Given this list of marker genes SFRP2, SATB1, PBXIP1, BBS12, NRXN3, CABCOCO1, SOX21, ESRRG, ARHGAP6, BDNF, RNF181, PTPN7, BIRC8, TLE4, ADSS2, UBE2E4P, POU4F1, ASCL4, BAD, KBTBD12, NXPH4, SEZ6, DLG2, GUCY2C, ADGRB3, BCL11A, SAMM50, FBXW7, OTP, OLFM4, PELO, PAX8, MCAM, CPNE8, CHCHD7, ZHX3 (zinc fingers and homeoboxes 3), YWHAQ, CPA2, LMO2, SLC25A39, PPARGC1A, EXOC6, ELAVL2, GDF1, PYGM (NCBI Gene Id 82368), FAM193B, FAM167A, KCNH8 (potassium voltage-gated channel subfamily H member 8, NCBI Gene Id 131096), JMJD6, CYP7B1, KCTD6, ADAMTS6, SETD2, SH3KBP1, PHEX, RNF152, PROK2, CTSS, PXK, GNA13, GLRX5, SCAF11, CBLIF, GPC4, NNMT, HOXA5, AFF4 (ALF transcription elongation factor 4), HOXD3, FCHSD2, MRPL49, TMTC2, BSND, PCF11, CRIM1, FOXF2, KLF7, ACTB, REEP4, GDNF, TIAL1, ABCA12, DIAPH1, FBXO11, UTP4, ZFP91, PTMA, TMEM150A, RORA, TMEM35A, STRA6, DRD3, MXI1, ZFP36L1, FOXP2, WNT2, MAFG, RUNX3, BMPR2 (NCBI Gene Id 659), PHOX2B, RBFOX1, ASB4, IL1RAP, INO80D, TBX19, SEMA7A, PDGFB, SP8, LCOR, ZNF541 (NCBI Gene Id 84215), TUBA1A, HSCB, PALMD, MYCL, ZNF689, DCUN1D1, VIPR2, HTN1, ENPP2, CERS1, PTPN12, ATF4, RUNX1T1, AGAP2, ZFPM1, CNTF, FST, ZNF362, CDC42EP4, ZNF688, ULK3, ID3, LSAMP, S100A9, SCN3A, RIMS1, IGF1, RGS8, PLAG1, ITGA7, FBLN5, SCUBE3, B3GALT5-AS1, DYSF, SHANK2-AS3, TGIF1, ALOX12B, PDZD4, ITGA1, here is a description of the gene set: Comprehensive identification of all functional elements encoded in the human genome is a fundamental need in biomedical research. Here, we present a comparative analysis of the human, mouse, rat and dog genomes to create a systematic catalogue of common regulatory motifs in promoters and 3' untranslated regions (3' UTRs). The promoter analysis yields 174 candidate motifs, including most previously known transcription-factor binding sites and 105 new motifs. The 3'-UTR analysis yields 106 motifs likely to be involved in post-transcriptional regulation. Nearly one-half are associated with microRNAs (miRNAs), leading to the discovery of many new miRNA genes and their likely target genes. Our results suggest that previous estimates of the number of human miRNA genes were low, and that miRNAs regulate at least 20% of human genes. The overall results provide a systematic view of gene regulation in the human, which will be refined as additional mammalian genomes become available. Human Gene Set: RAAGNYNNCTTY_UNKNOWN studied in species Homo sapiens from publication Xie X, Lu J, Kulbokas EJ, Golub TR, Mootha V, Lindblad-Toh K, Lander ES, Kellis M (PMID 15735639) Genes having at least one occurrence of the highly conserved motif M125 RAAGNYNNCTTY in the regions spanning 4 kb centered on their transcription starting sites. The motif does not match any known transcription factor binding site.